Given this list of marker genes Kat2b, Klf11, Mknk2, Smchd1, Zfp1008, Skic3, Fundc1, Zdhhc15, Tab2, Esrrg, Bnip3l, Tmem196, Zfp974, Tbc1d16, Arglu1, Dnajb12, Pcmtd1 (NCBI Gene Id 71455), Fbxo33, Grin2a, Epas1, Dcdc2a, Pik3c2b, Rgs20, 2810004N23Rik, Smarcc2, Atp10a, Zfp827, Crebzf, Kntc1, Zfp236, Frem1, Trmt6, Zdhhc21, Avl9, Myo18a, Slc1a2, Slitrk6, Tm4sf1, Paip2b, Cd14, Pde1a, Gm14391, Acvr2a, Slc4a11, Gabrb2, Fhod3, Dlgap1, Mael, Fchsd2, Atp6ap2, Srsf2, Gng7, Ppp1r17, Rskr, Gfra1, Tmem170b, Sav1, Rexo1, Gm4724, Met, Tmem276, Sf3b4, Lmx1a, Msl2, Gria2, Samd5, Gm6710, Parpbp, Kcnq5, Rgs4, 1700019D03Rik, Pou2f1, Ccnt2, Prox1, Gm14434 (NCBI Gene Id 668039), Hnrnpk, Pkn2, Plekhb2, Cep97, Sec13, Zfp644, En1, Gm2026, Chodl, Tbl1xr1, Pcdhb13, Mgat5, Zfp626, Aasdhppt, Sox6, Abcb6, Shoc2, Gm14308, Nudt19, Ago1, Rabl3, Pbx3, Septin2, Phactr2, Gm14326, Ssh2, Slc4a4, Orc4, Dcdc2c, Prkar2b, Gorab, Zfyve16, Stk26, Polr2m, Prr18, Dcp2, Ugdh, Lrrn4, Secisbp2l, Iffo1, Zfp286, Obi1, Gm14325, Phf6, Rp2, Chek1, Pga5, Lin28b, Cep70, Map3k2, Bicd1, Chd7, Zfx, Nherf1, Wdr33, Arhgap42 (Rho GTPase activating protein 42), here is a description of the gene set: Mouse Gene Set: MIR_7673_3P from publication Chen Y, Wang X (PMID 31504780) Genes predicted to be targets of miRBase v22 microRNA mmu_miR_7673_3p in miRDB v6.0 with MirTarget v4 prediction scores > 80 (high confidence targets). species: Mus musculus